The following is a description of a gene set: species: Mus musculus Mouse Gene Set: GOBP_ICOSANOID_SECRETION The controlled release of icosanoids, any of a group of C20 polyunsaturated fatty acids from a cell or a tissue., and this is the list of marker genes: Oc90, Pla2g6, Oxt, Pla2g2d, Pla2g2a, Lhcgr, Pla2g2f, Bdkrb2, Pla2g12b, Syk, Il1a, Tnfsf11, Acsl4, Agtr2, Hrh3, Nos2, Pla2g12a, Drd2, Anxa1, Nmb, Edn1, Hrh2, Pla2g4a, Drd4, Pla2g2c, Map2k6, Pla2g2e, Il1b, Sstr4 (NCBI Gene Id 20608), Nmur2, Lep, Atp5pf, Mif, Pnpla8, Pla2g4f, Pla2g1b, P2rx7, Pla2g3 (phospholipase A2, group III), P2ry2, Avpr1b, Mapk9, Tnfrsf11a, Cyp4a32, Ptges, Ace (NCBI Gene Id 11421), Cyp4a31, Ptgs2, Drd3, Cyp4a10, Kiss1r, Pla2g10 (phospholipase A2, group X), Pla2g5, Abcc4, Proca1, Pla2r1 (NCBI Gene Id 18779), Ntsr1